The following is a description of a gene set: Human Gene Set: GOCC_HIGH_DENSITY_LIPOPROTEIN_PARTICLE studied in species Homo sapiens A lipoprotein particle with a high density (typically 1.063-1.21 g/ml) and a diameter of 5-10 nm that contains APOAs and may contain APOCs and APOE; found in blood and carries lipids from body tissues to the liver as part of the reverse cholesterol transport process., and this is the list of marker genes: APOA2, APOA5, APOA4, APOC2, APOE, HPR, CETP, PON1, APOC4, LCAT, APOM, APOA1, APP (NCBI Gene Id 351), PLTP, LIPC, HDLBP, APOC1, APOF, APOO, SAA4, APOH, SAA1, APOL1, CLU, PLA2G7, APOC3, SAA2 (serum amyloid A2)